Given this list of marker genes IL15, NFIL3, KAT7, GAS6, SP3 (NCBI Gene Id 6670), SLAMF1, PBX1, STAT5A, PGLYRP3, RASGRP1, PTPRC, PGLYRP2, TOX, IL21, PGLYRP1, MERTK, RABL3, TYRO3, TUSC2, ZBTB1, STAT5B, AXL, IL15RA, ID2, PIK3CD, ZNF683, PRDM1 (NCBI Gene Id 639), here is a description of the gene set: species: Homo sapiens The process in which a relatively unspecialized cell acquires the specialized features of a natural killer cell. Human Gene Set: GOBP_NATURAL_KILLER_CELL_DIFFERENTIATION